Given this list of marker genes SMNDC1, VCL, POMP, C17orf58, ACER3, KRAS, SCN7A, ENDOU, GPCPD1, TMEM97, LDLRAD3, OSTM1, FIGN, CELF1 (NCBI Gene Id 10658), SLC44A1, STARD13 (StAR related lipid transfer domain containing 13), COPS8, ARHGEF7, MYB, CREB5 (cAMP responsive element binding protein 5), USP37, GDNF, KIF1C, SHISA9, RNF170, DMRTA1, BMP2K, RAMAC, NKAIN2, PAN3, STT3B, ABTB3, NABP1, MIER3, TRA2B, WASHC4, RHOBTB1, ARPP19, CCDC34, TAF9B, MDM4, TEX2, SLF2, SLC17A6, RCBTB1, KCNJ13, WWP1, TMEM265, EIF4G2, UBE2D2, LIMCH1, YTHDF3, AMDHD1, AGO1, UGGT1, USP15, PJA1, SLC5A1, NSL1, FASLG, TES, SLC4A1AP, SLITRK5, KIF5B, ROR1, KBTBD8, CHRNA9, RPP14, CDH2, ATP2C1, FMO1, GNG12, SELL, NEK1, CARMIL1, AFF2, F13A1, SLC12A2, MICOS10 (mitochondrial contact site and cristae organizing system subunit 10), BMPR1A, DUSP16, TM9SF3, MRAP2, PPP1CB, MORF4L2, MSI2, GPR137C, MLLT3, ST13, ULK2, SEL1L, GJA1, DGKH, TM9SF2, ATAD2B, KRT1, AP1S3, ZNF33B, TFCP2, GPR12, CD24, UBE2V1, C18orf63, RAB2A, ITGA6, NRXN1, GOLT1B, EPHA4, INPP5F, HIPK3, PRPF40A (NCBI Gene Id 55660), CD274, OGG1, CRAMP1 (cramped chromatin regulator homolog 1), ACSL3, PARP14, TULP4, BRWD3, POU4F1, ELK4, STXBP5L, CRYL1, CDC5L, API5, KIAA0408, TJP1, HNRNPK, MGAT4B, L3MBTL3, PRKAB2, CP, TAF2, NEDD4, HMMR, PTPN13, NUP50, MAP3K8, C2orf68 (NCBI Gene Id 388969), SCAPER, STXBP5, FGFBP3 (fibroblast growth factor binding protein 3), CDK12, REST, BCL11B, FNIP2, SDCBP (syndecan binding protein), SPOCK1, RBMS3, DCUN1D4, ITM2B, QDPR, LEPR, SUZ12, SPATS2L, DET1, RNF38, AMOTL2, TEKT3, TMEM64, PPFIA2, SSH2, ST8SIA3, UBE2K, ZNHIT6, BICRAL, ACADSB, FUT9, FSD1L, PLCL1, FLRT2, TEAD1, DNAJB14, PCSK5, TTC3, SRGAP1, CD40LG, CAB39 (NCBI Gene Id 51719), ZNF24, CYP51A1, SLC10A7, PDE4D, ZNF532, DENND6A, ZNF302, ASAP2, LPIN1, MECP2, WAC, PPP3R1, PTPN11, ADAT2, KHDC4, TBL1XR1, LMO7, ZEB1, RAP2C, EPHA5, ITGB6, ATP8A1, CDC14A (cell division cycle 14A), ODC1, CBL, FAT1, COQ9, PHEX, MED14, GRAMD2B, ABCA9, TRAM1, SLC7A11, SSBP2, SPATA13, CRYZL1, ZIC3, PBX1, RAPGEF2, CITED2, MAGI1, MSANTD4, CALM1, CLDN10, here is a description of the gene set: studied in species Homo sapiens from publication Chen Y, Wang X (PMID 31504780) Genes predicted to be targets of miRBase v22 microRNA hsa-miR-105-5p in miRDB v6.0 with MirTarget v4 prediction scores > 80 (high confidence targets). Human Gene Set: MIR105_5P